The following is a description of a gene set: Human Gene Set: WP_MYOMETRIAL_RELAXATION_AND_CONTRACTION_PATHWAYS species: Homo sapiens Myometrial relaxation and contraction pathways, and this is the list of marker genes: CAMK2G, JUN (NCBI Gene Id 3725), RGS17, GSTO1, ITPR3, PRKACA, RYR2 (NCBI Gene Id 6262), FOS, ADCY3, OXTR, RGS19, PRKAR1A, ACTC1, GNB2, IGFBP6, MYL4, ACTA2, RGS2, RGS6, GNG7 (NCBI Gene Id 90274), IGFBP2, PRKAR2A, GNG12 (G protein subunit gamma 12), RXFP1, MAFF, PDE4D, YWHAH, RGS9, GRK6, GNB4, CREB3, IGFBP5, LINC02210-CRHR1, RGS5, DGKZ, ITPR1, GRK5, LPAR1, RGS1 (regulator of G protein signaling 1), PRKACB, ATF5, PKIB, MYLK2 (myosin light chain kinase 2), NOS3, PDE4B, GNB1, CALM1, RLN1, IGFBP4, RGS3, PKIG, CRCP, GNB5 (G protein subunit beta 5), CALM3, IGFBP3, ITPR2, IL6, RYR3, PRKCE, PLCG1 (NCBI Gene Id 5335), IL1B, ATP2A3, ADCY8 (NCBI Gene Id 114), GNGT1, PRKCD, ADM, GRK4, RAMP2, ATF6B, PRKAR2B, YWHAG, RGS14, GNG3, PLCB3, CRHR1 (corticotropin releasing hormone receptor 1), ACTA1, OXT, ATF4, ADCY5, ATP2A2, CAMK2B, ATF3, IGFBP1, CAMK2D, SFN, PKIA, RAMP1, PRKCG, GNG4, YWHAE, YWHAB, ADCY1, CRH, RXFP2, ATF1, RGS18, GNAQ, ADCY6, ADCY4, CNN1, RGS10, GJA1, RGS4, CALM2, CALD1, SP1, ATF2, ADCY9, GPR182, GUCA2B, ETS2, MYL2, GNG13, CACNB3, CNN2, GNB3, ACTG1, CAMK2A, RGS7, SLC8A1, PRKCA, PRKCQ, ARRB2 (NCBI Gene Id 409), RGS16 (regulator of G protein signaling 16), PRKD1, NOS1, PRKAR1B (protein kinase cAMP-dependent type I regulatory subunit beta), YWHAQ, PRKCB (NCBI Gene Id 5579), PLCD1, PRKCH, GUCY1A1, CREB1, RAMP3, GNG8, RGS11, ACKR3, GABPB1, PRKCZ, PLCG2, ACTB, GNG5, GABPA, ADCY2, RGS20, ARRB1, YWHAZ, CORIN, GUCA2A, NFKB1, GNG11, CALCA, RYR1, GNAS (NCBI Gene Id 82944), GNG2, ADCY7